Given this list of marker genes CASP3, SOD1, CASP9, BAK1, CYCS, BAX (NCBI Gene Id 581), BCL2, APAF1, here is a description of the gene set: studied in species Homo sapiens Pathway Definition from KEGG: SOD1* -| BCL2 -| (BAX,BAK1) -> CYCS == APAF1 -> CASP9 -> CASP3 Human Gene Set: KEGG_MEDICUS_VARIANT_MUTATION_CAUSED_ABERRANT_SOD1_TO_INTRINSIC_APOPTOTIC_PATHWAY Mutation-caused aberrant SOD1 to intrinsic apoptotic pathway. Pathway ID: N01135. Pathway type: Variant. Pathway class: nt06464 Amyotrophic lateral sclerosis.